The following is a description of a gene set: Mouse Gene Set: GOBP_MITOTIC_G1_S_TRANSITION_CHECKPOINT_SIGNALING studied in species Mus musculus A cell cycle checkpoint that detects and negatively regulates progression from G1 to S phase as part of a mitotic cell cycle., and this is the list of marker genes: Wac, Rps27l (ribosomal protein S27-like), Dgkz, Sde2, Ccnd1, Fbxo31, Rfwd3, Ptprv, Rpa2, Trex1, Plk3, Prkdc, Trp53, Gigyf2